Given this list of marker genes PLEK, CCDC126, TFB1M, S100A6, LGALS3, EPB41L4A, CCNG1 (cyclin G1), VSIR, SDAD1, IL1RL1, M6PR, CHST15, MYADM, CEMIP2, RNASE4, S1PR4, TM6SF1, LGALS1, CERS4, DIPK1A, ICOS, LCA5, PRDM1, MEIOC, PTPRE, SANBR, IL10RB, CCR10, GLIPR1, RIPPLY3, MMD, TOR4A, SRPK3, CD247, PGAP6, USP28, COBLL1, CRIP1, MYT1, KCNQ5, ATXN1L, CRTC3, FUT11, AKAP7, RPA1, IQGAP2, GALNT7, CCR4, CCR5, SAMD11, GLRX, PTPN4, SMCO4, LNX2, PPAT, S100A11, CPM, KCNK6, ADO, TRMT10C, CPSF3, GRHL1, TEC, RNF6, ARL5A, PPP2R5A, ZBTB33, ZNF655, ADGRB2, KLHL6, IL18, NRIP1, CORO2B, CIPC, SLBP, SNX4, LGMN, ARHGEF6, ZNF764, EMC2, MYO1F, BSCL2, CD79B, HSPB1, ITGAV, AVPR2, SNAI2, RBPMS2, IL10RA, SSR1, TIPARP, CDC25B, ARHGAP31, STX12, ASB2, TNFRSF13C, LCLAT1, CHD7, MST1, NCK2, PACC1, SMPDL3A, LRBA, MAN2A1, PLEKHA8, ATP10D, HYCC1, PLPP1, WDR81, HLA-DRB1, TKTL1, SLC25A20, PDE2A, ELMO1, FBXO41, VAMP5, PPM1J, NHSL2, CYBB, CD48, GNA15, LRRC71, UBASH3B, CD74, POU2AF1, MTRF1L, TMEM154, ENOPH1, CHDH, CD22, H6PD, KLF10, MAN1A2, SERPINB1, IGLC7, RAP1A, GPR25, WDR3, MAF, TRAT1, SLC25A33, ADAM8, ANKRD6, RNF146 (NCBI Gene Id 81847), CR2, CASS4, CYFIP1, KLRG1, RPH3AL, PRR14L, PPP4R1, TBC1D14, LRRC66, DAPP1, FZD5, GCNT1, KBTBD11, ERO1B, FCMR (Fc mu receptor), NQO1, ZDHHC23, NXPE3, CLIP1, GCHFR, IGHM, ACTR2, LCP1, SESN1, PEAK1, HUS1, EIF4EBP2, LATS2, FCER2, RIPK1, P2RX7, SDCBP2 (syndecan binding protein 2), CERKL, CDKN2C (NCBI Gene Id 654235), SMYD4, ALOX15B, IL10, NUAK2, ELOVL5, GIMAP7, CDIPT, NOTUM, ITSN1, TMEM51, IKBIP, ARRB1, FAM89A, SEC24D, TSR1, SHE, IKZF3, TBX21, RAPGEF5, TMEM126A, CCR2, ECI1, here is a description of the gene set: studied in species Homo sapiens Genes up-regulated in CD4 T conv over-expressing: FOXP3 versus PBX1 and FOXP3. Human Gene Set: GSE40274_FOXP3_VS_FOXP3_AND_PBX1_TRANSDUCED_ACTIVATED_CD4_TCELL_UP from publication Fu W, Ergun A, Lu T, Hill JA, Haxhinasto S, Fassett MS, Gazit R, Adoro S, Glimcher L, Chan S, Kastner P, Rossi D, Collins JJ, Mathis D, Benoist C (PMID 22961053) The transcription factor FoxP3 partakes dominantly in the specification and function of FoxP3+ CD4+ T regulatory cells (Tregs), but is neither strictly necessary nor sufficient to determine the characteristic Treg transcriptional signature. Computational network inference and experimental testing assessed the contribution of several other transcription factors (TFs). Enforced expression of Helios or Xbp1 elicited specific signatures, but Eos, Irf4, Satb1, Lef1 and Gata1 elicited exactly the same outcome, synergizing with FoxP3 to activate most of the Treg signature, including key TFs, and enhancing FoxP3 occupancy at its genomic targets. Conversely, the Treg signature was robust to inactivation of any single cofactor. A redundant genetic switch thus locks-in the Treg phenotype, a model which accounts for several aspects of Treg physiology, differentiation and stability.